The following is a description of a gene set: from publication Mikkelsen TS, Hanna J, Zhang X, Ku M, Wernig M, Schorderet P, Bernstein BE, Jaenisch R, Lander ES, Meissner A (PMID 18509334) species: Mus musculus Genes with low-CpG-density promoters (LCP) bearing the tri-methylation mark at H3K4 (H3K4me3) in MCV6 cells (embryonic fibroblasts trapped in a differentiated state). Human Gene Set: MIKKELSEN_MCV6_LCP_WITH_H3K4ME3 Somatic cells can be reprogrammed to a pluripotent state through the ectopic expression of defined transcription factors. Understanding the mechanism and kinetics of this transformation may shed light on the nature of developmental potency and suggest strategies with improved efficiency or safety. Here we report an integrative genomic analysis of reprogramming of mouse fibroblasts and B lymphocytes. Lineage-committed cells show a complex response to the ectopic expression involving induction of genes downstream of individual reprogramming factors. Fully reprogrammed cells show gene expression and epigenetic states that are highly similar to embryonic stem cells. In contrast, stable partially reprogrammed cell lines show reactivation of a distinctive subset of stem-cell-related genes, incomplete repression of lineage-specifying transcription factors, and DNA hypermethylation at pluripotency-related loci. These observations suggest that some cells may become trapped in partially reprogrammed states owing to incomplete repression of transcription factors, and that DNA de-methylation is an inefficient step in the transition to pluripotency. We demonstrate that RNA inhibition of transcription factors can facilitate reprogramming, and that treatment with DNA methyltransferase inhibitors can improve the overall efficiency of the reprogramming process., and this is the list of marker genes: ZFAND6, ADAMTS13, ADGRG1, PIPOX, STYXL2, MRPS21, LGALS3BP, ZMYM2, KCNIP3, ZBP1, MSLN, XDH, PDZK1IP1, CES2, ZFP57, NR1H5P, PTPRVP, ROBO4, PRELP, MR1, ACY3, EVI5, TGM3, PRICKLE3, GALNT15, CSF3, SH3KBP1, RNASE1, CYP2J2, PLEKHA6, OAS2, PRX, FGD4, USP54, RNF151, DAB2IP, MYOT, GSTM1, SCARA5, FXYD3, CFH, GCNT3, XAF1, RNF123, ELOVL1, FGFBP1, GBGT1 (globoside alpha-1,3-N-acetylgalactosaminyltransferase 1 (FORS blood group)), RORC (RAR related orphan receptor C, NCBI Gene Id 6097), ZNF583, KCNN4, PLEKHS1, ALDH3B1, NOTCH4, TNFSF10, VWA5A, MARK2, WARS1, GPR21, CHST4 (NCBI Gene Id 10164), IQSEC2, KRTDAP, GLRX, TAPBPL, ANGPTL2, SLC29A1, THEM5, GGNBP1, GPSM3 (G protein signaling modulator 3), ALDH3A1, TMEM176B, GPA33, CFAP126, C1RL (complement C1r subcomponent like), SERPINB9, LST1, GLMP, CCDC120, TMEM248, TNS2, PINLYP, IFI35, SYTL1, LAPTM5, SLC13A2, FABP7, DQX1, CRB1, SNX10, IL7R, IFITM1, KLK11, TNS4 (tensin 4), MAB21L3, BTC, VTCN1, GPR35 (G protein-coupled receptor 35), SIPA1L3, CCDC9, SLC25A45, SERPINB8, CAB39, MUC1, ZSCAN2, TNFSF13, GPR173, COL6A1, CHIT1, SLFN12, GPANK1, RUFY4, RBM10, LGALS9, TRIM21, NHERF2, KIF1C, TMEM176A, ALDH1A1, ISG20, C20orf96, GBP2, PCOLCE, IL17RE, PRRG2, S100A3, IL17RC, ARAP1, TREX1, IKBKE, KCNK7, NYAP1, AKNA, C2orf80, DAPK3, CD244, HEXIM2, ANXA1, ARHGEF11, ZBTB20, UNC13D, TRIM40, SYNE3, ARHGDIB, TNKS1BP1, NPPB, PSTPIP1, RIPOR2, EMP3, URB2, LBP, C6orf118, MYO1G, COX7A1, ASPDH, RAB17, ANKRD49, RSAD2, AOC1, PSPN, OTOP2, TBC1D10C, MRGPRF, SPEF2, CYP4F8